The following is a description of a gene set: Mouse Gene Set: GOMF_CCR2_CHEMOKINE_RECEPTOR_BINDING Binding to a CCR2 chemokine receptor. species: Mus musculus, and this is the list of marker genes: Defb15, Msmp (microseminoprotein, prostate associated), Ccl7, Ccl2, Nup85, Ccl12 (NCBI Gene Id 20293), Defb34, Ccr2